The following is a description of a gene set: TCF-1 is an HMG family transcription factor which is known to be critical for T cell development. We discovered that it has a unique role in suppressing malignant transformation of developing thymocytes at early stages. We identified ID2 and LEF-1 as key TCF-1 target genens in tumor suppression. We used microarrays to detect gene expression changes in WT and TCF-1 deficient DN3 thymocytes as well as T cell lymphoma cells developed in TCF-1 KO mice. Genes down-regulated in TCF7 knockout: DN3 thymocytes versus T cell lymphoma cells. studied in species Homo sapiens Human Gene Set: GSE33292_DN3_THYMOCYTE_VS_TCELL_LYMPHOMA_FROM_TCF1_KO_DN from publication Yu S, Zhou X, Steinke FC, Liu C, Chen SC, Zagorodna O, Jing X, Yokota Y, Meyerholz DK, Mullighan CG, Knudson CM, Zhao DM, Xue HH (PMID 23103132), and this is the list of marker genes: C14orf132, STAU2, TMSB15A, CLIC4, NHERF1, SLC17A1, RAD51AP1, PTPRE, ADAM23, GALNT2, SPRED2, CCNA1, KIF14, ASL, SOS2, MYEF2, TYRP1, DPYD, KIF20B, MYO16, GNG12, LITAF, FBN2, GJB1 (gap junction protein beta 1), FOXF2, LINC00342, GADD45A, STAG1, WASF1, SGSH, AFF1, ERI2, PAK4, LAMA5, ZNF548, MLXIP, ARHGAP11A, PRTN3, CD5, SCARB2, VAPB, MPPED1, SMC4, CD38, ZCCHC14, ITPRID2, TACC2, AASS, MRC2, SNPH, ADAM5, TMEM187 (transmembrane protein 187), CREBL2, PIK3R3, ARHGAP19, TAF11, MYB (NCBI Gene Id 4602), WNT10B, ROCK1, AFF3, FNBP1L, CRX, PPP1R26, CENPA, CTSO, KNG1, KCNA5, MTMR6, KCNJ10, EPS8, SLC25A4, SPICE1, PLXNB1, S1PR4, TTK, KRT86, GUCY1B1, CEMIP, IL2, ZEB2, RPL39L, RIMS3, PIM1, SERPINB8, CDC27, CHEK2, COL9A2, VDR (NCBI Gene Id 7421), ROR1, MAN1A2, BCL2L1, IFIT5, TNP2, ARFGAP3, YBX3, KIF23, CDKN2C, ZCCHC24, SLC24A1, BARD1, TMX4, JMJD6, RP2, ADH1C, TNFRSF9, UGT2B11, SNAPC3, FZD2, CDKN2D, MAU2, STC2, TNK1 (tyrosine kinase non receptor 1), CTF1, KBTBD2, P4HA2, CAMSAP1, BCL9, EPHX2, TNNI1, DIO2, ARID3A, IFNAR1, SUN2, CDC25C, SVEP1, APOBEC3B, GPSM2, DDAH2, DNAAF9, IL12B, CELSR3, PMM1, CTSW, RDH16, LPGAT1, SYNE2, CTRC, CEACAM3 (NCBI Gene Id 1084), DLG3, MPP2, DGCR5, LY6G6C, CYP2A7, IL16, GPRC5A, SLC25A40, GRM5, ANXA5, PHTF2, BRD1, NCAPD3, TNFRSF17 (NCBI Gene Id 608), TTR, ASXL1, CLOCK, SEC14L1, DCTN3, ENC1, IQGAP2 (IQ motif containing GTPase activating protein 2), SLC17A2, ANGPT2, ATP8A2, TNFAIP1, ELF3, TOM1L2, GTPBP10, PDLIM7, MTM1, LGR5, PRR4, DMXL2, REXO5, C15orf39 (NCBI Gene Id 56905), HOXC11, BTAF1, HFE, NEK2, POU1F1, CILK1, RAPGEF5, STK38, NKX2-8, MFGE8, PLA2G5, SPINK1 (NCBI Gene Id 6690), MAPK11, GAS7, SLC30A3, SERPINF1, SMC2, SIM1, H4C2, APBB2, MRPS14, GORASP1, BUB1, TSSK2, B3GALNT1, KRT83